Given this list of marker genes IL2RA (NCBI Gene Id 3559), RIDA, BCO1, IL33, SULF1, MGP, GIMAP4, P2RY13, FYB1, RGS1, CD38, CTSS, CCR5, LIPA, CCDC144A, SAMSN1, RSPO3, IGFN1, LXN, PDCD1LG2, OLFM4, MRC1, KBTBD8, CD2 (CD2 molecule), RHOH, FAM111B, ENSG00000280433, ENPP3, MT-ND1, CCR1, GPR171, SLAMF6, TENT5C, IGLL5, PIM2, TRAT1, NSA2, FCRL5, SIGLEC8, F13A1, LUM, CXCL9, TCEAL8, CD53, CAPN6, CADM3, MSR1, TCEAL9, CDH11, COMP, TNFRSF9, TBCA, PLBD1, CD8A, SERTM2, TLR7, TNFSF8, MZB1, PLOD2, LCP2, CDK1, ARHGDIB, SNX3, CP, MMP13, CHRDL1, GZMA, CETN3, NCKAP1L, CD86, ADAMDEC1, LCP1, IFIT3, SAMD9, ABRACL, RPL26, TFEC, ANKRD1 (ankyrin repeat domain 1), BCL2A1 (BCL2 related protein A1), PSMB9, CD48, TM4SF1, CYTIP (NCBI Gene Id 9595), CYBB, FKBP5, SIRPG, CD84, CLECL1P, GBP4, SH2D1A, TMED2, MMRN1, PLEK, BCHE, LAMP5, OLR1 (oxidized low density lipoprotein receptor 1), DNAJA1, MT-ND2, RPL35A, CLIC2, TLR8, C1S, SRGN, CD8B, SIRPB1, ASPH, FCGR1A, WARS1 (NCBI Gene Id 7453), GAPT, ITGB1, SPARCL1, SLC6A15, MANEA, SPP1, GPR34, CTSK, SFRP4, CRTAM, CCL18, GNG11, B2M, FPR3, GBP1, TCIM, SDCBP, VSIG4, CPA3, UBD, LYZ, SAMD9L, MS4A6A, PYHIN1, JCHAIN, NPL, CLEC4E, FRG1, GBP5, AIF1, ELL2, S100A10, LY86, KLRC4, C3, ITK, SERINC1, TCN1, MAP1B, KMO, EHHADH, CD3G, FCGR3A, LAX1, QPCT, GBP2, GZMK, CARD16, KLRC4-KLRK1, LTV1, HSD17B6, CD28, CLTRN, MNDA, KIF20B, CD52, IFI16, CD3E, C3AR1, RPL36A, CLEC2B, SF3B6, KYNU, SELL, SLC4A4, EVI2B, CD3D, ICOS, RPL22L1, SSB, APOC1, CXCL11, MT-ND4, MS4A4A, CFH, HLA-DOB, RNASE6, CXCL10, SNRPB2, HLA-DQA2, DAPP1, BANK1, P2RY10, PLAAT4, VNN2, FCER1G, AGT, HLA-DPA1, NUDT11, CXCL13, GPR174, HSPA13, CADM1, CASP1, RPS27A, MARCO, POLR2K, IKZF3, POSTN, CD180, OR2I1P, IFI44L, PTPRC, HLA-DRA, APOL6, PLA2G7, SEMA3C, MMP1, KTN1, SFRP2, TMIGD3 (transmembrane and immunoglobulin domain containing 3), MFAP5, IL7R, DNAJB4, VCAM1 (NCBI Gene Id 7412), GIMAP2, TNFSF13B, TMEM255A, IBSP (NCBI Gene Id 3381), UQCRB, CD200R1, PTPN22, CCL5, EMB (NCBI Gene Id 133418), COL14A1, SLAMF7, here is a description of the gene set: from publication Zhang X, Zhao J, Yin X, Liang J, Wang Y, Zheng L, Tan P, Lin Y, Xu N, Zhu S, Chen J, Zhao J, Hu X, Pan X, Nie L, Zhang M, Chen Y, Zhang Y, Liu H, Dai J, Wang Z, Liu H, Ni Y, Rupp NJ, Moch H, Sheng X, Gong K, Liu X, Chen Z, He Z, Wang Y, Xu L, Liu M, Zhou H, Tang B, Huang R, Wei Q, Li X, Liu J, Yao J, Liao B, Liu Z, Shen P, Chen N, Zeng H, Sun G (PMID 40355427) Fumarate hydratase-deficient renal cell carcinoma (FH-deficient RCC) is a rare yet highly lethal kidney cancer. To deepen understanding of FH-deficient RCC, the authors conduct a comprehensive integrated genomic study. The authors analyze the association of FH alteration patterns with tumor heterogeneity and develop a CpG site-specific methylation signature for precise identification of FH-deficient RCC. Transcriptomic analysis unveils three distinctive molecular subtypes characterized by enrichment of immune/Angiogenic/Stromal (C1), WNT/Notch/MAPK (C2), and proliferation/stemness (C3) pathways, respectively. Tumors in C1 derive the most substantial survival benefit from a combination of immune checkpoint blockade (ICB) and anti-angiogenic therapy. Tumors in C2 display moderate response to this therapeutic approach. In contrast, tumors in C3 exhibit an unfavorable response to anti-angiogenic monotherapy and its combination with ICB. These findings contribute to a profound understanding of the aggressive nature of FH-deficient RCC, offering insights into potential precision medicine approaches for disease management. Human Gene Set: ZHANG_FH_DEFICIENT_RCC_C1_VS_OTHERS_UP studied in species Homo sapiens Genes upregulated in the C1 subtype of FH-deficient RCC relative to C2 and C3 subtypes.